The following is a description of a gene set: Mouse Gene Set: VANLOO_SP3_TARGETS_UP studied in species Mus musculus Genes up-regulated in E12.5 hearts from mice with SP3 knockout compared to the wild type organ. Mice lacking the zinc finger transcription factor specificity protein 3 (Sp3) die prenatally in the C57BL/6 background. To elucidate the cause of mortality we analyzed the potential role of Sp3 in embryonic heart development. Sp3 null hearts display defective looping at embryonic day 10.5 (E10.5), and at E14.5 the Sp3 null mutants have developed a range of severe cardiac malformations. In an attempt to position Sp3 in the cardiac developmental hierarchy, we analyzed the expression patterns of >15 marker genes in Sp3 null hearts. Expression of cardiac ankyrin repeat protein (Carp) was downregulated prematurely after E12.5, while expression of the other marker genes was not affected. Chromatin immunoprecipitation analysis revealed that Sp3 is bound to the Carp promoter region in vivo. Microarray analysis indicates that small-molecule metabolism and cell-cell interactions are the most significantly affected biological processes in E12.5 Sp3 null myocardium. Since the epicardium showed distension from the myocardium, we studied expression of Wt1, a marker for epicardial cells. Wt1 expression was diminished in epicardium-derived cells in the myocardium of Sp3 null hearts. We conclude that Sp3 is required for normal cardiac development and suggest that it has a crucial role in myocardial differentiation. from publication van Loo PF, Mahtab EA, Wisse LJ, Hou J, Grosveld F, Suske G, Philipsen S, Gittenberger-de Groot AC (PMID 17923686), and this is the list of marker genes: Dmc1, Nupr1, Trib3, Macrod1, Itga4, Serpinb2, Tcfl5, Rbm45, Pnliprp2